The following is a description of a gene set: part of: Post-translational protein modification Small Ubiquitin-like MOdifiers (SUMOs) are a family of 3 proteins (SUMO1,2,3) that are reversibly conjugated to lysine residues of target proteins via a glycine-lysine isopeptide bond. Proteomic methods have yielded estimates of hundreds of target proteins. Targets are mostly located in the nucleus and therefore SUMOylation disproportionately affects gene expression.<br>SUMOs are initially translated as proproteins possessing extra amino acid residues at the C-terminus which are removed by the SUMO processing endoproteases SENP1,2,5. Different SENPs have significantly different efficiencies with different SUMOs. The processing exposes a glycine residue at the C-terminus that is activated by ATP-dependent thiolation at cysteine-173 of UBA2 in a complex with SAE1, the E1 complex. The SUMO is transferred from E1 to cysteine-93 of a single E2 enzyme, UBC9 (UBE2I). UBC9 with or, in some cases, without an E3 ligase conjugates the glycine C-terminus of SUMO to an epsilon amino group of a lysine residue on the target protein. SUMO2 and SUMO3 may then be further polymerized, forming chains. SUMO1 is unable to form polymers.<br> Conjugated SUMO can act as a biinding site for proteins possessing SUMO interaction motifs (SIMs) and can also directly affect the formation of complexes between the target protein and other proteins.<br>Conjugated SUMOs are removed by cleavage of the isopeptide bond by processing enzymes SENP1,2,3,5. The processing enzymes SENP6 and SENP7 edit chains of SUMO2 and SUMO3. species: Homo sapiens Reactome Pathway: SUMOylation, and this is the list of marker genes: RNF168, RELA, NCOR2, PGR, NUP155, SEH1L, NUP37, NUP58, NUP153, VHL, TFAP2C, SUMO2, NUP160, NUP107, SUMO1, TP53 (NCBI Gene Id 7157), TFAP2B, PARK7, NR1H3, HDAC2 (NCBI Gene Id 3066), BRCA1, PCNA, WRN, CTBP1, CBX8, FOXL2, SP3, NFKBIA, NUP133, CETN2, STAG2, TFAP2A, NR3C2, HERC2, NUP35, NUP42, AURKB, DNMT3B, PIAS4, MTA1, SMC5, NSMCE4A, SMC6, ESR1 (estrogen receptor 1), TP53BP1, BLM, MITF, NR3C1, H4C1, POM121 (NCBI Gene Id 9883), NR2C1, DDX17, HDAC4, THRA, SAFB, NSMCE3, RANGAP1, ZNF350, RPA1, NUP98, EIF2AK2, RAD52, TOP2B, RORA, CDKN2A, INCENP, ZNF131, CASP8AP2, NR1H4, NUP88, PIAS1 (protein inhibitor of activated STAT 1), AURKA, TPR, NUP210, SENP5, ING2, NUP93, DAXX, RARA, PPARA, SATB1, DDX5, NR1H2, NDC1, CBX5, EID3, NR1I2, PIAS3, SATB2, PPARG, CBX4, MRTFA, NR5A1, STAG1, NUP50, PHC3, AAAS, NUP54, IKBKG, DNMT3A, NUP214, POM121C, RANBP2, SMC1A, RWDD3, NPM1, XRCC4, SIN3A, NSMCE1, VDR, UBA2, HDAC7, PHC1, SP100, CHD3, HIC1, HIPK2, HDAC1, NCOA1, NUP188, NFKB2, MDC1, SEC13, UHRF2, MDM2, CREBBP, SENP2, SUMO3, CBX2, BMI1, PPARGC1A, NR4A2, NUP85, TOP1, NUP43 (NCBI Gene Id 79700), TOPORS, NSMCE2, SCMH1, PHC2, NOP58, ZBED1, RAE1, HNRNPK, TRIM28, TRIM27, PARP1, TDG, PML, BIRC5, SENP1, PCGF2, IKBKE, NCOA2, SAE1, PIAS2, NRIP1, THRB, XPC, RXRA, RING1, RNF2, RAD21, EP300, NUP205, UBE2I, AR, SMC3, DNMT1, NUP62, SUZ12, HNRNPC, MBD1, TOP2A, L3MBTL2, CDCA8, NR5A2